Given this list of marker genes MYC, CCND2, BCL2, PIM1, CCNE1, CCND3, CCND1, here is a description of the gene set: STAT5 targets in hematopoietic signaling. Hematopoiesis is the cumulative result of intricately regulated signaling pathways that are mediated by cytokines and their receptors. Proper culmination of these diverse pathways forms the basis for an orderly generation of different cell types. Recent studies conducted over the past 10-15 years have revealed that hematopoietic cytokine receptor signaling is largely mediated by a family of tyrosine kinases termed Janus kinases (JAKs) and their downstream transcription factors termed STATs (signal transducers and activators of transcription). Aberration in these pathways, such as that caused by the recently identified JAK2V617F mutation, is an underlying cause for diseases such as leukemias and other myeloproliferative disorders. This recent discovery, when coupled with the fact that STATs are activated by oncoproteins such as BCR-ABL, underscores the importance of the JAK-STAT pathway in both normal cellular development and disease states. species: Mus musculus from publication Baker SJ, Rane SG, Reddy EP (PMID 17934481) Human Gene Set: BAKER_HEMATOPOESIS_STAT5_TARGETS